Given this list of marker genes CFAP210, MZF1, MLEC, FBXL20, KCNC2, SULT1C2, WDR20, NEK7, ITGB8, RERE, ATAD1, SATB1, RBM19, ESR2, GPM6B, CDH11, CACNA1E (NCBI Gene Id 777), RGS7BP, CNOT2, RAB6A (RAB6A, member RAS oncogene family), NCMAP, ATOSA, PDE1C, PHTF2, DNM1L, HCFC2, ADRA1A, PTPRO, GZF1, SPOCK2, COMMD3-BMI1, POLG, CD99, ZNF282, SULT1C3, CYP21A2, CREB5, RNF103-CHMP3, PRDM6, TEF, MKI67, PHIP, TESMIN, BLVRB, MDH2, GABRA4, HNRNPR, SPRR2F, BEND4, CA13, NANOS1, RNF144A, UBFD1, SHISAL1, WDFY2, PIGN, C3orf70, SLC8A3, TXNDC8, CPSF6, CPM, GRM6, DDI2, WBP2, DUOXA1, GC, SIT1, ELP3, RNF114, ZDHHC17, CRYZ, EPAS1, C4orf17, CERS6, SSX2IP, PPARGC1A, MBNL2, NRP1, ELOVL6, AMOT, PRKD3 (NCBI Gene Id 23683), CLRN1, KRTAP9-3, MAP7D2, EBF3, BMI1, CHMP3, HMGXB3, PPP1R3A, COX15, SRGAP1, PAX5, GUCY1B1, KRTAP9-9, MED14, OXR1, HS3ST2 (NCBI Gene Id 9956), TRMT10B, IGF2BP3, HMG20A, SPTLC1, G6PC2, MTMR2, CUL3, CAMKK2, VSIG10, DYNLT5, here is a description of the gene set: from publication Chen Y, Wang X (PMID 31504780) studied in species Homo sapiens Human Gene Set: MIR3928_5P Genes predicted to be targets of miRBase v22 microRNA hsa-miR-3928-5p in miRDB v6.0 with MirTarget v4 prediction scores > 80 (high confidence targets).